The following is a description of a gene set: Genes down-regulated in ductal carcinoma vs normal ductal breast cells. BACKGROUND: Invasive ductal and lobular carcinomas (IDC and ILC) are the most common histological types of breast cancer. Clinical follow-up data and metastatic patterns suggest that the development and progression of these tumors are different. The aim of our study was to identify gene expression profiles of IDC and ILC in relation to normal breast epithelial cells. METHODS: We examined 30 samples (normal ductal and lobular cells from 10 patients, IDC cells from 5 patients, ILC cells from 5 patients) microdissected from cryosections of ten mastectomy specimens from postmenopausal patients. Fifty nanograms of total RNA were amplified and labeled by PCR and in vitro transcription. Samples were analysed upon Affymetrix U133 Plus 2.0 Arrays. The expression of seven differentially expressed genes (CDH1, EMP1, DDR1, DVL1, KRT5, KRT6, KRT17) was verified by immunohistochemistry on tissue microarrays. Expression of ASPN mRNA was validated by in situ hybridization on frozen sections, and CTHRC1, ASPN and COL3A1 were tested by PCR. RESULTS: Using GCOS pairwise comparison algorithm and rank products we have identified 84 named genes common to ILC versus normal cell types, 74 named genes common to IDC versus normal cell types, 78 named genes differentially expressed between normal ductal and lobular cells, and 28 named genes between IDC and ILC. Genes distinguishing between IDC and ILC are involved in epithelial-mesenchymal transition, TGF-beta and Wnt signaling. These changes were present in both tumor types but appeared to be more prominent in ILC. Immunohistochemistry for several novel markers (EMP1, DVL1, DDR1) distinguished large sets of IDC from ILC. CONCLUSION: IDC and ILC can be differentiated both at the gene and protein levels. In this study we report two candidate genes, asporin (ASPN) and collagen triple helix repeat containing 1 (CTHRC1) which might be significant in breast carcinogenesis. Besides E-cadherin, the proteins validated on tissue microarrays (EMP1, DVL1, DDR1) may represent novel immunohistochemical markers helpful in distinguishing between IDC and ILC. Further studies with larger sets of patients are needed to verify the gene expression profiles of various histological types of breast cancer in order to determine molecular subclassifications, prognosis and the optimum treatment strategies. from publication Turashvili G, Bouchal J, Baumforth K, Wei W, Dziechciarkova M, Ehrmann J, Klein J, Fridman E, Skarda J, Srovnal J, Hajduch M, Murray P, Kolar Z (PMID 17389037) species: Homo sapiens Human Gene Set: TURASHVILI_BREAST_DUCTAL_CARCINOMA_VS_DUCTAL_NORMAL_DN, and this is the list of marker genes: SERPINA1 (NCBI Gene Id 5265), ARMCX4, KRT5, TNC, SLC25A37, CRYAB, YBX3, SBSPON, CFAP70, ELF3, CDRT4, EGFR, PTPN21, DUSP1, TTC6, USP31, TRIM29, OPRPN, ITGB8, JCHAIN, SOCS5, KRT17, PAPLN, HOXA3, ZNF667, LIN37, GATM, KCNC4, CHIC2, SCN4B, CYB5R2, FZD7, MAFF, ANXA1, MYLK, KBTBD6, RND3, HOXA9, IQCA1, CLDN8, KRT23, MUCL1, ANKRD18A, COL17A1, FBXO32, DST, ALDH1A3, GPC3, ZDHHC3, IGHA1, MYH11, BHLHE41, MET, MICAL3, PAK3, LAMB3, KIF27, EDN3, SFRP1 (secreted frizzled related protein 1), MGST1, MYBPC1, SF1, TCIM, RRAD, MEGF6, EGR1, KRT6B, MIR101-1, TAC1, PLEKHS1, SAA1, ENOSF1, STEAP3, MRPS25, SPRED1, CARMN, SOX9, PIGR, MGP, GPM6B, CNTNAP3, TRIM2, PSMA3-AS1, ZNF204P, PTX3, CFD, SYNM, SLC18B1 (NCBI Gene Id 116843), AMY1A, KRT7, PDLIM3, RHOQ, CMTM8 (NCBI Gene Id 152189), PER1, LTF, CCL28 (NCBI Gene Id 56477), CD59, CAV2, APOD, ID4, OXTR, ATF3, SPIN3 (spindlin family member 3), SCGB1D2, DEPP1, ELF5, RBPMS, PKP4, MIR205, LINC01128, SYNPO2, CDC14B, SOD2, DSC3, TNFRSF10B, CHL1, EHF, PALMD, GABARAPL1, CNN1, CX3CL1, TRAPPC11, MAP2, HOTAIRM1, ZNF542P, ULK4, PTN, TF, KRT14, TUBB2B, ITGB4, MFSD14CP, FOSB, SHISA2, MAMDC2, GABRE, PDZK1IP1, TSHZ2, TM4SF1, SAMD5, ZNF37BP, FHOD3, ZBTB16, TGFA, MAOB, CHI3L1, BBOX1, FOS (Fos proto-oncogene, AP-1 transcription factor subunit), ECRG4, SLC12A2-DT, TRIP6, RARRES1, BCOR, CP, DLG5 (discs large MAGUK scaffold protein 5), SORBS2, RAB27A, ADAMTS5, MIR23AHG, NFIB, DNAAF9, NDRG2, AK5, CCDC9B, GABRP, ACTA2, KRT16, ATP10D, HMGCS2, GRAMD2B, SCGB2A2 (NCBI Gene Id 5661), MID1, CYP4X1, RAPGEF2, KRT15, ST3GAL6, LAMC2, RCAN1, ENSG00000255367, KIT, RNFT1, ENSG00000269825, DSG3, MMP7, TFAP2B, ATP1A2, KLK7, TAGLN, ANPEP, CTSV, CFI, CLDN11, CSNK1A1, NCOA7, PDZK1, CDH3, TFPI2, FAM110C, CMYA5, PI15, VTCN1, PLEKHH2, SEC14L1, ZNF462, ACTG2, LAMA3, ENTREP1